Given this list of marker genes MYC, IGF2, IGF2BP3, ACTB, CD44, H19, IGF2BP2, IGF2BP1, here is a description of the gene set: studied in species Homo sapiens Reactome Pathway: Insulin-like Growth Factor-2 mRNA Binding Proteins (IGF2BPs/IMPs/VICKZs) bind RNA Insulin-like Growth Factor-2 mRNA Binding Proteins (IGF2BPs) bind specific sets of RNA and regulate their translation, stability, and subcellular localization. IGF2BP1, IGF2BP2, and IGF2BP3 bind about 8400 protein-coding transcripts. The target RNAs contain the sequence motif CAUH (where H is A, U, or, C) and binding of IGFBPs increases the stability of the target RNAs. part of: Metabolism of RNA